The following is a description of a gene set: species: Mus musculus STAT3 targets in hematopoietic signaling. Human Gene Set: BAKER_HEMATOPOIESIS_STAT3_TARGETS Hematopoiesis is the cumulative result of intricately regulated signaling pathways that are mediated by cytokines and their receptors. Proper culmination of these diverse pathways forms the basis for an orderly generation of different cell types. Recent studies conducted over the past 10-15 years have revealed that hematopoietic cytokine receptor signaling is largely mediated by a family of tyrosine kinases termed Janus kinases (JAKs) and their downstream transcription factors termed STATs (signal transducers and activators of transcription). Aberration in these pathways, such as that caused by the recently identified JAK2V617F mutation, is an underlying cause for diseases such as leukemias and other myeloproliferative disorders. This recent discovery, when coupled with the fact that STATs are activated by oncoproteins such as BCR-ABL, underscores the importance of the JAK-STAT pathway in both normal cellular development and disease states. from publication Baker SJ, Rane SG, Reddy EP (PMID 17934481), and this is the list of marker genes: MYC, FAS, PIM1, HIF1A, PIM2, CCND1 (cyclin D1), MMP9, BCL2, CCNA2, CCND2, CCND3, BIRC5, MCL1, MMP2, NSG1